Given this list of marker genes RFLNB, MARCHF8, SLC4A1, PI3, CPA3, EPB42, IGF1R, here is a description of the gene set: studied in species Homo sapiens Genes down-regulated in blood vaccinated vs control in adults (23-48) after exposure to Live attenuated vaccine TC-83, time point 7D Venezuelan equine encephalitis virus (VEEV) is an important human and animal alphavirus pathogen transmitted by mosquitoes. The virus is endemic in Central and South America, but has also caused equine outbreaks in southwestern areas of the United States. In an effort to better understand the molecular mechanisms of the development of immunity to this important pathogen, we performed transcriptional analysis from whole, unfractionated human blood of patients who had been immunized with the live-attenuated vaccine strain of VEEV, TC-83. We compared changes in the transcriptome between naive individuals who were mock vaccinated with saline to responses of individuals who received TC-83. Significant transcriptional changes were noted at days 2, 7, and 14 following vaccination. The top canonical pathways revealed at early and intermediate time points (days 2 and 7) included the involvement of the classic interferon response, interferon-response factors, activation of pattern recognition receptors, and engagement of the inflammasome. By day 14, the top canonical pathways included oxidative phosphorylation, the protein ubiquitination pathway, natural killer cell signaling, and B-cell development. Biomarkers were identified that differentiate between vaccinees and control subjects, at early, intermediate, and late stages of the development of immunity as well as markers which were common to all 3 stages following vaccination but distinct from the sham-vaccinated control subjects. The study represents a novel examination of molecular processes that lead to the development of immunity against VEEV in humans and which may be of value as diagnostic targets, to enhance modern vaccine design, or molecular correlates of protection. Human Gene Set: ERWIN_COHEN_BLOOD_VACCINE_TC_83_AGE_23_48YO_VACCINATED_VS_CONTROL_7DY_DN from publication Erwin-Cohen RA, Porter AI, Pittman PR, Rossi CA, DaSilva L (PMID 27870591)